The following is a description of a gene set: from publication McMurchy AN, Gillies J, Gizzi MC, Riba M, Garcia-Manteiga JM, Cittaro D, Lazarevic D, Di Nunzio S, Piras IS, Bulfone A, Roncarolo MG, Stupka E, Bacchetta R, Levings MK (PMID 23169781) Genes up-regulated in activated CD4 T cells expressing: wildtype versus mutant form of FOXP3. Investigation of the role of FOXP3 in CD4+ T effector cells. FOXP3 is transiently upregulated in T effector cells under activation. This temporary expression in Teff cells is insufficient to suppress expression of reported targets of FOXP3 repressor activity. The role of FOXP3 in T effector cells remains unclear. We used microarray analysis to detail the differentially expressed genes between FOXP3 wild type and 2T>C(mut) clones and identified classes of up-regulated or down-regulated genes based upon FOXP3 expression. Human Gene Set: GSE41087_WT_VS_FOXP3_MUT_ANTI_CD3_CD28_STIM_CD4_TCELL_UP studied in species Homo sapiens, and this is the list of marker genes: DUSP1, SRSF10, FYN, ATF3, UTRN, HLA-DPA1, PLAT, HLA-DQB1, ITGAE, LTA4H, PNRC1, SYNGR3, EIF5, TSC22D3, DIAPH1, DDX17, CGGBP1 (CGG triplet repeat binding protein 1), JUNB, LY6G6E, TLR8, BID, PROM1, HLA-DQA1, TICAM1, ATG13, LGALSL, HLA-E, PTGIR, FOXO3, H2BC10, EREG, CLEC5A, LCP1, CCR7, WDR73, C5AR2, KYNU, AQP9 (aquaporin 9), H2BC5, NFKBIE, HLA-DMA, C1orf56, FCN1 (ficolin 1), ZNF672, SLCO3A1, KHNYN, BIRC3, CXCR4, RPS14 (ribosomal protein S14), TMEM43, PDE3B, AFTPH, HLA-DRB1, CRIM1, NFKB1, HCP5, ICOSLG, VEGFA, CD5, HGS, ERO1B, DGKA, MOB1A, SLC16A6, BACH1, GK3, CD44, PIGL, KCNJ15, MARCKSL1, FHL3, S100P, SDC2, ANPEP, CST6, TANK, IL10RA, S100A12 (S100 calcium binding protein A12), GNG5, KMT2D, AHR (aryl hydrocarbon receptor), HCK, PDE4B, RFTN1, JADE2, CD83, TPT1, PITPNB, CHST11, FLVCR2, SRC, RNPS1, ISG20, VWF (von Willebrand factor), CD9, PLD2, CXCL13, MSC, CCL22 (NCBI Gene Id 6367), CFP, FBXW7, MLN, PBOV1, PDLIM7, CCR5 (NCBI Gene Id 727797), SPEN, H2AC6 (H2A clustered histone 6), CST7, ETV6, ATP1A1, H2BC12, PRR16, PPM1F, BCL3, WARS1, SOD2, CLEC4E, ARAP3, CFLAR, SYT17, SLC7A11, GK, IRF1, IL2RG, CSF2RB, KCTD15, MREG, NIBAN1, DDX21, PABPN1, SMAD3, NFKBIA, NOTCH2NLA, SLC2A6, GNG11, LAMP3, RPL10, PRR14, PTGER2, TTLL4, NCF2, KAT6A, DNAAF1, HLA-DRA, TJAP1, HOMER2 (NCBI Gene Id 9455), IDO1, ORAI2, TOP3A, AKT3, CCR2, OLR1, ZBTB44, SDC4, SLAMF7, POLDIP3, LORICRIN, LRCH3, FTH1P5, CHST2, TRAF1, C15orf39, TNFAIP3, DNAJB5, LYZ, ICAM4, HLA-F, CYTIP, CSF2RA, HLA-DPB1, NPLOC4, CYP27A1, ACVR2A, TNFRSF4, NAB1, TNFSF4, IRF4, DUSP2, PHLPP2, IDS, GPR183, TNIP1, GRIK1, TG, SETD1B, MAP3K14, EBLN2, BTG2, RELB, GLIPR1, STARD5, TTC17, RBM5, PF4, MAMLD1